Given this list of marker genes SLC28A2, AQP9, SLC28A3, SLC29A3, SLC28A1, SLC29A2, SLC29A1, here is a description of the gene set: Enables the transfer of pyrimidine nucleobases, one of the two classes of nitrogen-containing ring compounds found in DNA and RNA, from one side of a membrane to the other. Human Gene Set: GOMF_PYRIMIDINE_NUCLEOBASE_TRANSMEMBRANE_TRANSPORTER_ACTIVITY species: Homo sapiens